Given this list of marker genes COG8, SIGMAR1, NDRG1, HK1, GNPTG, INF2, GNPTAB, SPTAN1, PDXK, HSPB1, here is a description of the gene set: An abnormality of the hand characterized by metacarpophalangeal (MCP) hyperextension and proximal interphalangeal (PIP) and distal interphalangeal (DIP) flexion. The position of the affected hand is said to resemble a claw. studied in species Homo sapiens Human Gene Set: HP_CLAW_HAND_DEFORMITY Claw hand deformity